The following is a description of a gene set: Abnormal formation of the keratinocytes of the epidermis characterized by persistence of nuclei, incomplete formation of keratin, and moistness and swelling of the keratinocytes. Human Gene Set: HP_PARAKERATOSIS Parakeratosis species: Homo sapiens, and this is the list of marker genes: NIPAL4, ERCC6, CLDN1, SPINK5, PMVK (phosphomevalonate kinase), GLS, MVK, MVD (mevalonate diphosphate decarboxylase), ATP2A2, LDHA, FLG2, TRPV3, KRT13, IL36RN, NSDHL, KLK11, KRT10, CYP4F22, TRPM4, NLRP1, MBTPS2, ELOVL1, KRT74, CDSN, PERP, POMP, PIK3CA, LORICRIN, TGM1, KRT5, CARD14, DSP, RHBDF2